Given this list of marker genes UBE2D1, TP53AIP1, CSNK1D, CSNK1G1, DAXX, SKP2, HUWE1, RPL11, PTPA, PIN1, KAT8, AKT1, NEDD8, CDK2, CSNK1G2, MDM2, DYRK2, PPP2CA, ATM, YY1, CCNG1, RPL5, SMYD2, CSNK1A1, CDKN2A, TRIM28, RCHY1, FBXO11, KMT5A, ATR, COP1, CSE1L, MAPK9, KAT5 (NCBI Gene Id 10524), PRKCD, CSNK1G3, RPL23, ABL1, GSK3B, CHEK2, CSNK1E, USP7 (NCBI Gene Id 7874), EP300, MAPK8, RASSF1, KAT2B, PRMT5, TTC5, PPP1R13L, TP53, MDM4, CREBBP, MAPK14, E4F1, CCNA2, HIPK2, CHEK1, SETD7, PPM1D, here is a description of the gene set: p53 pathway studied in species Homo sapiens from publication Schaefer CF, Anthony K, Krupa S, Buchoff J, Day M, Hannay T, Buetow KH (PMID 18832364) Human Gene Set: PID_P53_REGULATION_PATHWAY